The following is a description of a gene set: Mouse Gene Set: GOBP_L_LEUCINE_CATABOLIC_PROCESS species: Mus musculus The chemical reactions and pathways resulting in the breakdown of L-leucine, 2-amino-4-methylpentanoic acid., and this is the list of marker genes: Bckdk, Hmgcl, Mccc1, Mccc2, Hmgcll1, Auh, Ivd